The following is a description of a gene set: Human Gene Set: GOCC_IONOTROPIC_GLUTAMATE_RECEPTOR_COMPLEX A multimeric assembly of four or five subunits which form a structure with an extracellular N-terminus and a large loop that together form the ligand binding domain. The C-terminus is intracellular. The ionotropic glutamate receptor complex itself acts as a ligand-gated ion channel; on binding glutamate, charged ions pass through a channel in the center of the receptor complex. studied in species Homo sapiens, and this is the list of marker genes: CACNG8, GRIN3A, SHISA7, CNIH3, GRIA4, SHISA8, GRIN2C, VWC2L, CNIH2, CACNG5, DLG4, GRIN2D, PTK2B, OLFM2, GRIN2B, SHISA9, GRIN1, GRIK1 (NCBI Gene Id 2897), ABHD12, GRIK5, GRIK3, GRIA2, CACNG3, GRIN2A, GRID1, GRIA1, GRIA3, VWC2, CACNG4, CPT1C, CACNG2, DLG3, GRID2, GRIK2, EPS8, PORCN, GRIN3B, ABHD6, NRN1, SHISA6 (NCBI Gene Id 388336), CACNG7, SACM1L, GRIK4, OLFM3